Given this list of marker genes SNTB2, SKIL, PPRC1, SOCS3, MNDA, CCDC86, LRRFIP1, CD4, SERPINE1, JUNB, NAB2, MT1X, AK4, RGL1 (NCBI Gene Id 23179), NFIL3, FRMD6, PKD2, here is a description of the gene set: studied in species Mus musculus Genes up-regulated in 3T3-L1 cells (adipocyte) by insulin but displayed blunted response to insulin the insulin resistant cells. from publication Sartipy P, Loskutoff DJ (PMID 14530283) Human Gene Set: SARTIPY_BLUNTED_BY_INSULIN_RESISTANCE_UP We have employed microarray technology using RNA from normal 3T3-L1 adipocytes and from 3T3-L1 adipocytes made insulin-resistant by treatment with tumor necrosis factor-alpha to identify a new class of insulin-responsive genes. These genes continued to respond normally to insulin even though the adipocytes themselves were metabolically insulin-resistant, i.e. they displayed a significantly decreased rate of insulin-stimulated glucose uptake. Approximately genes/expressed sequence tags (ESTs) were screened. Of these, genes/ESTs were identified that became insulin-resistant as expected (e.g. Socs-3, junB, and matrix metalloproteinase-11). However, genes/ESTs continued to respond normally to insulin. Although some of these genes were previously shown to be regulated by insulin (e.g. Glut-1 and beta3-adrenergic receptor), other novel insulin-sensitive genes were also identified (e.g. Egr-1, epiregulin, Fra-1, and ABCA1). Real-time reverse transcription-PCR analysis confirmed the expression patterns of several of the differentially expressed genes. One gene that remained insulin-sensitive in the insulin-resistant adipocytes is the transcription factor Egr-1. Using an antisense strategy, we show that tissue factor and macrophage colony-stimulating factor, two cardiovascular risk factors, are downstream EGR-1 target genes in the adipocyte. Taken together, these data support the hypothesis that some signaling pathways remain insulin-sensitive in metabolically insulin-resistant adipocytes. These pathways may promote abnormal gene expression in hyperinsulinemic states like obesity and type II diabetes and thus may contribute to pathologies associated with these conditions.